The following is a description of a gene set: studied in species Homo sapiens Human Gene Set: chr1q23, and this is the list of marker genes: ENSG00000288775, DUSP12 (dual specificity phosphatase 12), FCRL5 (Fc receptor like 5), OR10J7P (olfactory receptor family 10 subfamily J member 7 pseudogene), SNHG28, KCNJ10, NR1I3, HSP90AA3P, RN7SL861P, SLAMF6P1, RXRG, KIRREL1, ENSG00000198358, BCAN, SPTA1, ETV3 (ETS variant transcription factor 3), GPATCH4, HSD17B7, HSPA6, IFI16, ELL2P1, CASQ1, NECTIN4, FCGR3B, NMNAT1P2, CD1A (CD1a molecule), CD1E, ENSG00000236656, ITLN1, VDAC1P9, ATF6-DT, OR6K6, HDGF, SDHC, MIR5187, OR10X1, SUMO1P3, TAGLN2, OR10AE1P, ARHGAP30, RNU6-171P, LMX1A-AS2, ATP1A2, ENSG00000272668, ADAMTS4, ATP1A4, USP21, OR10K2, PYDC5, OR10R1P, FCRL1, MIR556, FCER1A, FCGR2B, IGSF9, FCRL2, UQCRBP2, OR10J3, OLFML2B, LMX1A-AS1, LINC02819, HMGB3P6, NIT1, FCGR2C, OR10Z1, CADM3, MIR4259, OR10K1, MPZ, IGSF8, KCNJ9 (NCBI Gene Id 7820), METTL25B, PEA15, MRPS21P2, OR6K1P, VANGL2, FCRL6, FCRLA, ARHGEF11, C1orf226, OR10AA1P, SMU1P1, OR6K4P, NHLH1, TRNT1P1, NECTIN4-AS1 (NECTIN4 antisense RNA 1), COPA, OR10J4, RGS4, ENSG00000232188, OR6N2, OR2AQ1P, FCRL4, FCER1G, ENSG00000291226, RPS23P9, GLRX5P2, ETV3L, BCAN-AS1, RN7SL466P, PYHIN5P, RPL31P11, RRM2P2, CCDC190, RNA5SP62 (RNA, 5S ribosomal pseudogene 62), UHMK1, CYCSP52, CFAP126, OR6K3, OR6K2, PRCC, MPTX1, PIGM, LY9, OR10R3P, PBX1, SMIM42, OR10T1P, MIR765, PFDN2, CRP, CD5L, LINC01704, RNU5F-6P, NUF2, INSRR, SLAMF9, PPOX, ENSG00000232995, OR6N1, VSIG8, CRABP2, TOMM40L, ITLN2, SLAMF1, DEDD, B4GALT3, UAP1-DT, DDR2, UAP1, OR10T2, HMGN1P5, CD1D, MRPL24, AIM2, RNU6-481P, F11R, FCRLB, OR6Y1, DUSP23, MNDA, CD84, CADM3-AS1, DCAF8-DT, PYHIN1, BCAN-AS2, ISG20L2, RNU4-42P, FCRL3, ENSG00000295014, LINC01133, NTRK1, CD1B, ENSG00000238934, RNA5SP61, PRELID1P7, CFAP45, RGS5 (NCBI Gene Id 8490), FCGR2A, LRRC71, ENSG00000227741, PEAR1, CD244, NDUFS2, RN7SL612P, RNU6-755P, RNA5SP60, APOA2, OR6K5P, KLHDC9, TSTD1, HSPA7, PBX1-AS1, PPIAP37, EI24P2, ATF6, RPS23P10, OR10J2P, NES, DCAF8, HAPLN2, RNA5SP63, OR10J9P, SH2D1B, SLAMF7 (NCBI Gene Id 57823), OR10J8P, CD48, ACKR1 (NCBI Gene Id 2532), PEX19, LINC02772, UFC1, USF1, ENSG00000212161, OR10J5, CRPP1, MIR4654, NOS1AP (NCBI Gene Id 9722), PCP4L1 (NCBI Gene Id 654790), RPSAP18, LMX1A, OR6P1, RPL35AP7, SLAMF8, SPATA46, RAD1P2, RGS5-AS1, APCS, KRT8P45, SETP9, OR10J1, SLAMF6, SH2D2A, OR10J6P, NCSTN, OR10R2, FCGR3A, CD1C, KIRREL1-IT1